Given this list of marker genes KRTAP13-2, C16orf90, LMO7, MYOZ1, CTNNA1, C3orf70, EFEMP2, GJA1, POGLUT1, NLRP12 (NCBI Gene Id 91662), PLAC8, GPR161, BBS9, STAT2, VASH2, IZUMO1R, TRIP6, DBH, CITED1, ZNF239, OAZ2, KRT78, CTRC, NRIP2, RBMXL2, SIGIRR, ACOT7, GALNT4, SPHKAP, ANKRD46, PDZK1IP1, SCN3A (sodium voltage-gated channel alpha subunit 3), TM9SF4 (transmembrane 9 superfamily member 4), PHF23, NGF, SLC44A3, STOML1, SOX6, TAS1R3, FKBP14, GIMAP6, GPR85, ABCD2, NOXO1, PCSK1, CXCR6, LOX, SPRR2F, CASTOR1, ST6GALNAC1, ARRDC4 (arrestin domain containing 4), SSBP4, HSD17B14, GUCY2C, ENTPD1, CACNB2, FAH, TMC7, NPHP3, AK1, ALDOAP2, TCL1A, PEX11A (NCBI Gene Id 95687), HOXA4, ANGEL1, DNAJB12, LARGE1, OR7C1, SLC38A3, NTF4, GPX2, ABLIM1, MPP4, IQGAP2, BCL2L11, TIMP1, PPA1, GFRA1, PIK3CG, PGLYRP2, EHD3, RASSF2, TSPAN4, MXD1, B4GALNT2, OXNAD1, GBA1, MELTF, C12orf57, RHOH, PER3 (period circadian regulator 3), PCYOX1L, EXTL2, ARL4C, LGI1, MAP1S, ERN2, EAF2, AFF3, CASP6, PYROXD1, CTSW, TRIM66, UCP2, HIC1, PTPRCAP, PARP9, RABL2A, CTSF, NOVA1, CADM2, SH3BGRL3, FBXO6, MRPS21, SEMA7A, TBCD, FBXO34, RNASE4, FCRL1, TCF15, TBXA2R, THY1, PLBD2, C14orf180, EFNA3, CCS, AUH, SLAMF6, GPNMB, IBA57, PCDH8, CD3E, VPS37A, AGTR1, STX17, CD200R1, SLC7A4, WNT10B, SAMD9L, SPACA1, GTF2H5, ENPP2, PRR5, RPE65, TRAP1, SELENOP, NAALADL1, TNS1, MYO6 (NCBI Gene Id 4646), USP49, TRAPPC2L, CLPTM1L, NEB (NCBI Gene Id 4755), CXCR3, HTR1D, GABARAPL1, RIPK3, PCNX4, STK32C, SH3TC2, FOXO1, HECW1, USP31, VPS53, BASP1, CCDC181, KYAT3, ANXA1, COA4, AQP7, LRRTM2, CNGB3, KLHDC3, CD5L, PPP1R3G, TERB1, DUSP2, CD86, SH3PXD2B, ECM1, LOXL1, MAP6, NT5E, TEX12, PKHD1L1, SLC16A11, OXSR1, TPST1, ANXA6, CYP2F1, MGAT4EP, ASB2, HNF1A, NLRC3, SNX32, CCR5, XDH, CBFB, USB1, FAM217B, here is a description of the gene set: Triggering of B cell receptors (BCR) induces a massive synthesis of NFATc1 in splenic B cells. By inactivating the Nfatc1 gene and re-expressing NFATc1 we show that NFATc1 levels are critical for the survival of splenic B cells upon BCR stimulation. NFATc1 ablation led to decreased BCR-induced Ca++ flux and proliferation of splenic B cells, increased apoptosis and suppressed germinal centre formation and immunoglobulin class switch by T cell-independent antigens. By controlling IL-10 synthesis in B cells, NFATc1 supported the proliferation and IL-2 synthesis of T cells in vitro and appeared to contribute to the mild clinical course of Experimental Autoimmune Encephalomyelitis in mice bearing NFATc1-/- B cells. These data indicate NFATc1 as a key factor controlling B cell function. Genes up-regulated in B lymphocytes: wildtype versus NFATC1 knockout. studied in species Homo sapiens Human Gene Set: GSE21063_WT_VS_NFATC1_KO_BCELL_UP from publication Bhattacharyya S, Deb J, Patra AK, Thuy Pham DA, Chen W, Vaeth M, Berberich-Siebelt F, Klein-Hessling S, Lamperti ED, Reifenberg K, Jellusova J, Schweizer A, Nitschke L, Leich E, Rosenwald A, Brunner C, Engelmann S, Bommhardt U, Avots A, Müller MR, Kondo E, Serfling E (PMID 21464221)